The following is a description of a gene set: Human Gene Set: GOBP_BIOLOGICAL_PROCESS_INVOLVED_IN_INTERSPECIES_INTERACTION_BETWEEN_ORGANISMS species: Homo sapiens Any process evolved to enable an interaction with an organism of a different species., and this is the list of marker genes: NPC2, ZDHHC18, CCR5, NECTIN2, B3GALT5, RFPL2, TTC4, SPRR2A, TRAF2, PRKCE, PLA2G2A, NECTIN1, CXCL2, CYP1A1, CALR, TUSC2, TRAV1-2, CTSS, AVPR1B, BCL2, PTPN11, APOBEC3B, PTPN22, DUOX2, KPNA6, MEFV, SSC5D, KAT5, CD40, TRIM10 (NCBI Gene Id 95309), USP20, REG1A, HDAC2, NLRC3, CARD17P, UMOD, KLRC3, CCDC186, ZMYND11, SLC15A2, DEFB105A, STOX2 (NCBI Gene Id 93007), PSMA2, FKBP5, DEFB112, STMP1, MIR6869, PPP1R11, KLK7, MAP2K7, IFNL2, SASH1, NAPEPLD, PML, GKN2, CHMP4C, USP44 (NCBI Gene Id 84101), AP1G1, CARD9, COL6A1, KLHL6, NOTCH2, TRIM3, CCL19 (C-C motif chemokine ligand 19), DEFB133, SPAG11B (sperm associated antigen 11B), CFHR2, CCL7, NRP1, GARIN5A, PTPN2, NFKB2, HSPA8, EXOC1, THRSP, UBL7, MOG, NCAM1, TBXA2R, GPC3, SLC9A9, PLSCR4, TAB3, GRK2, LETMD1, SHMT2, CXCL13, CD300C, MIR520B, WWP1, MX2, TRIM54, C1S, RAB27A, WFDC2, NCR1, NR4A1, CHIT1, RAB20, YTHDF2, NLRC4, TRGV3, NOS3, PIK3C2G, CHMP1A, AXL, CCL4L2, CLEC2A, CDC73, TRIM49D2, PC, ITCH, IFNA4, DEFB1, FASLG, MIR146A, DEFB116 (NCBI Gene Id 245930), TSPO, PSMC3, SIGIRR, DEFB113, HTR2A, IFNL4, C4BPA (complement component 4 binding protein alpha), PPID, VAV1, CASP6, C9, ACTA2, GNLY, STXBP1, IFNA21, APOBEC3F, RAB14, CFH, CLU, TUBB4B, CD300E, SLC38A8, XPR1, SMPDL3A, TRIM25, TMEM126A, CAV1, EDN1, ITGB3, IRF3, TRAF4, PARP9, HCK, CSNK1A1, SEH1L, RPS6KB1, DEFA3, ARHGEF2, UVRAG (NCBI Gene Id 7405), TBX21, DEFB128, DDB1, TRIM4, EVPL, TREM1, AP1S1, DDX41, APOB, PSTPIP1, STOM, DUSP10, ULBP3, C8A, ATAT1, SIGLEC10, BPIFA2, MIR675, ADAM8, LITAF, MFHAS1, BTK, RPS6KA3, DEFB115, SH2D1B, IL33, FCGR1A, IDE, ATG5, PCBP2, VGF, FOS, WIPF1, DEFB103A, ERBIN, IFIT1, MARK4, IGHG2, AP3B1, PTPN6, IL17RC, NPLOC4, IL34, EEA1, INPP5K, CCL3, DAB2IP, MIR17, ADAM9, VAMP4, PLCG2 (NCBI Gene Id 5336), HRAS, CCDC92, DAPK3, NDUFAF4, NR1H3, TRIM26, IL17F, TLR5, DHX33, TARBP2, LAG3, IKBKB, HYAL1, ABCC8, IDO1, TRIM62, TOMM70, KIAA0319L, TICAM2, XCL1, NOD2, TRIM29, NLRP9, DEFA6, PMAIP1, SIRPA, NOTCH1, UNC13D, LYN, IL17A, APOBEC3A, MUC2, RAG2, WNT5A, NUGGC, LCE3C, ADAMTS5, TRIM11, FCRL3, BPIFB1, FAM3A, C1R, STAP1, NLRP2B, ACOD1, PELI3, OAS1, LCN2, TNFRSF1B, CPTP, SLFN13, SLC19A1 (solute carrier family 19 member 1), NOD1, TARM1, UBD, TBC1D20, STAB1, UFD1, MIR421, HLA-E, IGHG1, SYT11, IRAK2, EPX, GPR108, KLRC1, IL37, TICAM1, IL18, MLH1, ZBTB1, IGHE, SCARB2, COTL1, LILRA4, ABCA1 (ATP binding cassette subfamily A member 1), DAPK1, CTSL, CD47, PLPP6, CREBZF, SIGLEC1, CD2AP, NLRP1, ZDHHC20, IFNL1, ZCCHC3, KIR2DL4, DEFB114, SLAMF6, LY96, CD86, ANXA1, VWCE, HAVCR2, PRKN, FZD5, N4BP3, TRIM77, TRIM34, BATF3, FCER1G, C1QB, PAF1, ABCC9, KRT6A (NCBI Gene Id 93086), STMN1, PARP14, SPSB3, RNASE10, KCNK6 (potassium two pore domain channel subfamily K member 6, NCBI Gene Id 9424), TRIM64B, IRF5, AIM2, WFDC12 (WAP four-disulfide core domain 12), MED1, STING1, VPS18, FBXO9, CD81 (NCBI Gene Id 975), CD160, IFIT2, C6, RARA, CXADR, FYN, NLRP3, TKFC, MATR3, JAK3, TASL, OGT, TRGV4, RNASE12, VAPB, AKT1, DEFB135, TRAF3IP1, TGFB1, CHMP2B, F12, SLC46A2, RNASEL, UAP1, OPRK1, SP1, GLI2, NFKBIA, CCL21, CAPN2, TRIM43B, FCAR, ISG20, LSM14A, FBXO3, SLC1A5, MIR223, CCT5, CXCL1, CD46, CHMP4B, CD68, SERPINB3, IFNA10, IFNE, TLR2, USP15, DAO, MX1, TRIM23, SMARCB1, STAT2, RAC1 (NCBI Gene Id 5879), CST9L, CHRM2, MIRLET7I, CD58, GPAM, MOV10, TREX1 (three prime repair exonuclease 1), CR2, C15orf48, CBL, CD74, NQO1, LRAT, SMPD1, SLAMF8, C1RL, KIR3DL1, NUB1 (negative regulator of ubiquitin like proteins 1), KRT1, CRIPTO, TNFAIP3, MIR19B1, BPIFA1, C1QBP, DEFB131A, HLA-G, RNF144A, TRIM32, PLAA, CHMP6, PRKCD, GBF1, FURIN, ZDHHC11, ANPEP, PPP6C, LATS2 (NCBI Gene Id 95108), ARMC5, BPIFC, TRAV10, HMGB1, SBNO2, PI3, APPL2, DEFB108B, CTSG (NCBI Gene Id 1511), PUM1, EPS15, MAP3K7, CNOT7, DRD2, IL1RL2, TREM2, BCL3, EXT1 (NCBI Gene Id 3966), LYPD8, ZNRF4, TAB1, LILRA2, RAB7B, HK1, DEFB129, WFDC3, IRF2, DEFA4, CADM1, POLR3A, NPPB, UBA7, LRRC15, PRDX2, IFI44, EEF1G, WASHC4, DEFB104A, LTF, VAMP8, TRIM35, H2BC4, MIR200B, LEP, SUSD4, BIRC2, NCBP1, HPGD, EFNB2, PPARD, ECSIT, SYNCRIP, WFDC13, TRIL, GNRH1, CYBB, TARDBP, MAPKBP1, KYNU, MICB, MIR758, LDLR, WDFY1, TMEM120A, IFNG, SYK, CFD, LAMP1 (lysosomal associated membrane protein 1), NAALADL2, IL18RAP, CSNK2B, KLRC2, STAT1, CACTIN, AUP1, POU2F2, CD300H, NTS, PLG, WDR83, CHMP2A, TMEM229B, PPBP, EIF4E2, HP, AKAP12, TENT5A, RNF213, VAPA, IGKV3-20, LGALS3, ULBP1, FAU, FER, PDCD4, CD2, RBM47, LYST (NCBI Gene Id 1130), ZDHHC3, INPP5D, ESR1, IL10RB, HPGDS, ATG12, DEFB119, TRGV9, VNN1, TRDV2, TMF1, CDK6, EPRS1 (NCBI Gene Id 2058), RNASE8, DEFB105B, DEFB123, H2BC6, CST9, TFAP4, GBP5, DEFB103B, HSP90AA1, CCL24, GPR15LG, GJB6, HLA-B, HES1, FLNB, JAGN1, CHD7, CDK9, GPX4, EIF2AK4, NMI, PDE4B, WFDC10A, TRGV2 (NCBI Gene Id 6974), ZFP36, TRIM63, LRRC19, GIGYF2, CD55, SETD2, SERPINE1, KNG1, CCL15, SLC3A2, OTUD5, FABP4, RELA, EPHB2, GFI1, FGF10, IFNA17, STXBP2, POLR3D (RNA polymerase III subunit D), LY86, CORO1A, CX3CL1, CCL17, BANK1, AGBL5, GBP3, TRAV5, STAT5B, HMGCS2, RAB1A, APOE, OASL, MIR20A, DEFB124, LCE3B, HSPD1, CASP8, PIK3C3, TRIM27, CHMP3, XIAP, SCGB1A1, VIL1, H2BC8 (H2B clustered histone 8), CFL1, TRAF3IP2, FCGR3A, ADAR, REG3G, RNF19B, IFNA16, IKZF3, IL24, RNASE3, TRIM38, DEFB127, PDCD1LG2, CD1D, TNF, RNF5, SERINC5, MIR187, HLA-F, TRDV1, RFPL4B, DEFB107A, SHC1, TMEM45B, CLEC4A, PTGIR, TLR6, GTF2F1, MIR221, CLDN2, H2BC12, FADD, SHPK, DEFB108A, HIF1A, TPCN2, SRPK2, XRCC5, PRG2, MARCHF5, CLNK, MIR21, LACRT, GZMB, RNF216, CLDN9, KPNA3, IFNLR1, DAG1, ITGB6, VIP, PYDC5, ELMOD2, ADAMTS4, KCNJ8, MAP2K6, SPON2, RTP4, AKAP8, IL13, INSR (NCBI Gene Id 3643), IFITM2, LYPLAL1, HDAC6, KLRK1, TIFAB (TIFA inhibitor), NCF1, KIR2DS2, PPP2R3C, DROSHA, KCNK13, PGLYRP3, SPI1, SFPQ, RAB11FIP2, MIF, TRAV34, TRIM41, VPS37B, ATAD3A, ITGA2, WFDC10B, TPCN1, PVR, YTHDC2, NCBP3, SNX3, PYGL, DEFB121, AARS2, LYZL4, PRTN3, BNIP3, PPARG, PDPK1 (NCBI Gene Id 5170), LATS1, CHMP5, KIF5B, EIF2AK2, DDX1, NR1H4, AIF1, PLAC8, PCK1 (phosphoenolpyruvate carboxykinase 1), IL6R (NCBI Gene Id 3570), RPS15A, SAP30BP, WDFY4, UBE2K, TNFSF4, TRIM17, GSTP1, PTGER2, IFNA7, CRTAM, TLR10, ZNF502, UBQLN1, CDHR3, APCS, IFI16, LAMP2, SCNN1B, C4B, KLK3, KMO, ROMO1, REST (RE1 silencing transcription factor), BAX, ALPK1, SELPLG, TLR8, RNF39, ALAD, RFPL3, CXCL12, RAB5A (NCBI Gene Id 5868), SLC17A5, MR1, MIR766, ATG16L1, BRD4, IFIT1B, IFNAR1, LYZ, EGFR, MICA, ZDHHC12, H2BC10, ILF3, MSRB1, RBPJ, EFNB3, PGLYRP1, KRT16, RBCK1, IL10, DEFB106A, FN1, RNASE6, APOBEC3H, HMGB3, RNASE2, AIMP1, ZDHHC8, CHMP7, IFNA5, FBXL2, IER3, BANF1, APP, PF4, TMEM106A, TNFAIP8L2, GDI1, OAS3, ZNF697, RNF166, SLC15A4, MPO, LRG1, IL36B, TRAV20, RAB43, USP38, CYBC1, REN, GATA3, HTN3, PI4KA, ADH7, PIK3AP1, DHX58, RFPL4AL1, IL10RA, FOSL1, DHX16, CLEC5A, TNFRSF1A, ST13, SLC26A6, MAPK8, UNC93B1, GPS2, CD300LF, WAS, HVCN1, LRCH4, ABHD8, JAK1, SMIM30, IFNK, ZC3HAV1, LILRB1, NAGK, PSPC1, MECP2, NCF2, NMB (NCBI Gene Id 4828), PUM2 (pumilio RNA binding family member 2), HMGB2, PLA2G1B, ZNF683, HTN1, DMBT1, ACP5 (NCBI Gene Id 54), IPO5, NT5C3A, TLR7, CDC42, CD4, TRAV7, IKBKG, KRT8, TRIM28, ULBP2, RAF1, RFPL4A, CHMP1B, MIR30C1, RBBP9, IFI6, SFTPD, LGALS8, MIR200C, NCK1, AURKB, IPO7, MRC1, LGALS1, SLC30A8, HYAL3, NLRX1, CYSRT1, ITLN1, OPTN, DCST1, ANKRD17, MYH10 (NCBI Gene Id 4628), CFHR1, IFIT5, LRSAM1, HDAC1, MAP3K5, ABCF3, HNRNPUL1, IFNGR1, ILRUN, PPM1B, ANKRD1, DDX39A, LALBA, CD79B, ZYX, CSF3, DEFA5, IGF2R, NCR3, CLDN3, PPP1R14B, MMP12, CEP192, MIR4691, GIT1, CLDN1, APOA4, SERINC3, DEFB130B, MIR224, IFIH1, DEFB107B, TANK, GALP, FGFR2, CCL8, USP14, C5, MASP1, HSP90B1, PRLR, GSDME, RNF135, H2BC11, B2M, TRIM44, NOS2, CCDC88B, CLEC4C, SELENOW (NCBI Gene Id 6415), S100A9 (NCBI Gene Id 6280), SLFN11, LCE3A, CXCL11, TRIM40, TMEM43, MAPKAPK2, EIF5A, CHID1, ODC1, ABCD2, COLEC11, P2RX7, PIK3CG, RFPL1, NFKBIL1, HS3ST5, LGR4, MIR105-1, PIK3R6, VCAM1, FMO1, UPK1B, DCD, ATG14, JUND, TRIM14, TAX1BP1 (Tax1 binding protein 1), EREG, TMEM33, TF, IFITM3 (interferon induced transmembrane protein 3), CDK1, RASGRP1, RAB7A, RHEB, LPL, BPI, FGB, CCL3L3, TRIM49B, CASP7, MCOLN2, TREML1, PF4V1, TLR9, ARF1, EPG5, NLRP7, CEACAM1, TRIM49C, BECN1, EMILIN2, TAP2, RNASE11, TTLL12, C2, HMCN1, IL15, HLA-A, ELANE, NUP153, IRF1, ARG1, CTSB, CD96, CDK4, TRIB1, CCL27, ZNRF1, ZG16, MYD88 (NCBI Gene Id 4615, MYD88 innate immune signal transduction adaptor), ASS1, HLA-C, EXOSC4, PRSS2, HSP90AB1, FER1L6, BNIP3L, TRIM61, AQP1, GAPDH, EEF1A1, SEC61A1, ZNF175, TNFRSF4, F2, PHB1, MIR433, TRIM64, TRIML2, ANXA3, SLC52A2, CXCL9, USP7, ZC3H12A, DEFA1B, ERAP1, CTDP1, CD14, GSDMB, WRNIP1, CDC42EP4, AKIRIN2, PGLYRP2 (peptidoglycan recognition protein 2), CEP63, TMED1, HSPA1B, ITGAM, NFE2L2, SCIMP, STXBP4, KYAT1, SERPING1, GRB2, IFI35, MAPK14, DDX56, TRIM49D1, CSF1, SLC30A1, HEATR9, CXCL14, PAIP1, TRAV13-1, DEFB109B, OTOP1, MMP7, RASGRP4, TMEFF1, IL22RA1, AKAP1, BTBD17, PLA2G2F, PRKD1, PABPN1, TRIM51, RNASE7, RPS19, PRF1, BPGM, MYH9, IL1RAP, SERPINB4, SDHAF4, CCL26, TLR4, ITGB5, HPX, HDAC5, BST2, GPM6A, LSM5, CEACAM20, DEFB4A, SAMHD1, IFITM1, PQBP1, RAET1G, MIR26B, DEFB118, FCER2, ANG, SAMD9 (sterile alpha motif domain containing 9), N4BP1, SEC14L1, CD300A, DEFB110, MARCO, CLDN6, IFNA1, C7, PPM1E, CA5B, MAPK1, TYK2, CASP4, PRSS3, FOXP3, CFB, DHX36, PLEKHM2, USP50, CCL16, TRDV3, MIR181B1, IL36RN (NCBI Gene Id 26525), MIR95, BMP6, TRAV25, TRIM65, VEGFD, SPAG11A, TRAV4 (T cell receptor alpha variable 4), GPATCH3, IL36A, HERC6, CIITA, SRC, S100A14, NR1H2, EPO, GPR146, LYZL6, PCK2, SPN, BATF, PELI1, NR1I2 (NCBI Gene Id 8856), CYRIB, IFI44L, MAP2K3, KLRF2, TRIML1, CCNT1, NEK7, IFNA6, RPSA, FPR2, CYBA, DNAJC3, TRIM15, CAMP, PLD4, MST1R, RNF125, PGC, TAB2, TMEM255A, CXCL16, S100A7, TBKBP1, ADGRB1, NAIP, NR1D1, ADH5, TRIM5, MID2, MTOR (mechanistic target of rapamycin kinase), PPM1D, CCDC134, CALM1, IFNL3, FMR1 (NCBI Gene Id 5421), FFAR2, CTR9, KLRF1, S100A8, SH2D1A, CD37, GBP6, UPF1, MIR545, IL18BP, LAMP3, MIR141, LCN10, RAB29, DDIT4, CX3CR1, BCL2L1, CCL23, LDOC1, IGHA2, STX8, CLEC12B, TRAV27, JAK2, SKP2, CNPY3 (canopy FGF signaling regulator 3), TRAV35, PLA2G10, TRAV6 (T cell receptor alpha variable 6), IRF7, LAMTOR5, SMC6, CR1, CD209, TRAV26-1, DDX60L, PHB2, C3, SLC7A1, IGHG3, HPN, MALT1, CAV2, RIPK3, FBLN1, CHMP4A, HMGN2, CD6, APOL1, HEXIM1, FLOT2, CLEC4G, LGALS9, CSNK2A1, HAVCR1, SNW1, WFDC5, ERCC6, BCR, UBE2L6, UGT2A2, RNASE1, BSG, NECTIN4, CALCA (NCBI Gene Id 87044), TRAF6, KLK5, IL27, NLRP4, CSF2, NEDD4 (NEDD4 E3 ubiquitin protein ligase), IFNA8, ZNFX1, TRIM73 (tripartite motif containing 73), RNASE9, A2M, RBM14, CASP9, FASN, ARID5A, H2BC12L, CUBN, LPO, IL36G, TRAV1-1, MBL2 (mannose binding lectin 2), PPARA, NFKBIB, F2RL1, RNASE13, RPL39, LILRA5, IL31RA, PARP1, PLAAT3, IRF8, CGAS, CST9LP1, F2R, TRIM55 (tripartite motif containing 55), SHFL, GZMH, TLR3, RPL30, CCL14, FCN2, IL7R (interleukin 7 receptor), WWP2, CD244, CPT1A, HLA-DRB1, CRK, C4A (NCBI Gene Id 720), IGHD (immunoglobulin heavy constant delta), E2F1, BATF2, RRP1B, CLEC10A, MIR222, GSDMC, IRGM (immunity related GTPase M), PRKCA, HERC5, DEFB125, CXCL3, TRIM22, INS, C5AR1, RAB2B, TRIM6, ZDHHC5, MAP3K14, CCL2, EXOC7, ELP6, HADHB, LRP8, CH25H, CDK19, ENDOD1, ABCB1, ST6GALNAC1, TRIM69, CD80, EPHA2 (EPH receptor A2), RHOA, CCL18, TAC1, YWHAE (tyrosine 3-monooxygenase/tryptophan 5-monooxygenase activation protein epsilon), GATA6, GPER1, ADAMTS13, NINJ1, SERPINB9, DNAJA3, ITGB8, EXOC2, MMP8, APPL1, PPIB, PAK1, ACE2, DEFB136, TSLP, TRIM7, AVP, NLRC5, TNFSF8, FLOT1, LRRC14, SLPI, NMT2, CASP1, RPL13A, TNFRSF14, IL17RA (NCBI Gene Id 23765), PTPRC, CD207, IL25, TRAV26-2, RNASE4, ACTG1, NT5C2 (5'-nucleotidase, cytosolic II), ENO1, LYG1 (NCBI Gene Id 129530), CCL1, MIRLET7B, CMPK2, TRIM50, TRIM52, DTX4, LYG2, IKBKE, OTULIN, ATP4B, SCN7A, IFIT3, TRAF3IP3 (NCBI Gene Id 80342), GRN, CREBBP, S100A12, TLR1, CEBPE, CLPB, FCN1, CXCL5, STXBP3, HNRNPA0, CD274, NPC1, RIGI, GHSR, MIR520E, NEURL3, GSDMD, EDNRB, CARD8, REG1B, IFI27, IL6, CRCP, KPNA2, HCST, RSAD2, AGBL4, DEFB104B (defensin beta 104B), CSF2RB, ATF2, IFNW1, GZMA, SHARPIN, GBP2, TRAV30 (NCBI Gene Id 28652), PPP2CA, TRIM75, IL12A, ITGAV, PLSCR1, MEF2C, TRAC, REG3A, IL23R, POLR3G, ZDHHC1, TRIM64C, ATG7, CXCL6, IFNGR2, TRIM58, MAPK3, SARM1, PCYOX1L, CCL5, IL12RB1, CDC37, TOLLIP, NFKB1, PENK, BAK1, NRROS, WFDC9, IL21, SELENOK, KLRG1, PIM2, NECTIN3, FCGR2B, NOP53, CYLD, SLC10A1, DEFB130A, TRIM51G, CCL4, CD177, CPS1, IL4R, NOCT, MYO1C, CEBPB, CCL11, POLR3K, MIR128-1, SMAD6, FGL2, ADAM15, PTAFR, PRB3, PGLYRP4, CCL28, METTL3, NLRP6, PAK3, SLC7A5 (NCBI Gene Id 8140), MIR149, VPS4A, F11R, TMEM41B (transmembrane protein 41B), RDUR, BCL10, GCH1, CHGA, TPT1, DYNLT1, DDX17, TNIP1 (TNFAIP3 interacting protein 1), DEFB134, MTDH, COLEC12, ITGAX, TUBB, MIR140, DCLK1, TRGV8, KLRC4, LY9, CXCL10, CFHR5, AGTR1, MACROD2, NMBR, PIM1, INAVA, ZFYVE1, IRAK3, ITGB1, BSPRY, PJA2, KLRD1, HLA-DPA1 (NCBI Gene Id 7935), POLR3B, PLSCR3 (phospholipid scramblase 3), TRIM59, MAP4K2, RTN4, MUC7, ABL1, CCNK, CFI, PTGFR, IL1A, PIK3CD, DDX3X, CSF1R, PTPRS, UGT2A1, IFNB1 (interferon beta 1), TBK1, ITGA5, IFNA14, H2BC21, SNCA, IFNA2, PDE12, AICDA, LOXL1, HYAL2, SENP7, MIR342, SEMG1, TRAF3, DPP4, SLC52A1, CLEC4D, CEBPG, STX4, NKG7, TRIM56, ZBP1, PTGER1, DEFA1, TRGV5, MIR29B1, TRIM74, CCL20, PADI4, POU2AF1, AZI2, H2BC7, IGHA1, LGALS4, LYAR, WASL (NCBI Gene Id 8976), BMP2, VTCN1, TYROBP, STATH, ARG2, DEFB132, FAM20A, CFP, EP300, MMP3, CYP2E1, ZDHHC9, TRAFD1, SEC11A, LIAS, CHUK, DHX15, SRR, RAET1E, BPIFB3, STAT5A, KLRC4-KLRK1, PPIA, DUS2, CHMP4BP1, GYPA, USP29 (NCBI Gene Id 57663), LILRB2, PALM3, ADM (NCBI Gene Id 133), EPPIN, DEFB126, MGST2, MIR142, TRIM13, G3BP1, CRISP3, TRIM49, DHX9, CXCL8, PYDC2, PYHIN1, TRAV21, LACC1, SRPK1, CYP27B1, ITGB7, TRIM48, ACTR3, PPT1, ATP1B1, ZMPSTE24, SELENOS, TRIM43, NLRP10, PTPN1 (NCBI Gene Id 5770), POLR3C, SLC15A3, LTA, USP27X, SEMG2, GBP7, MIR19A, TP53, AQP4, PYDC1, GZMM, SMARCA4, CCL22, TRAV13-2, HSPA1A, SIN3A, TRIM8, NPY, TXK, CD84, TRAV36DV7, WFDC11, CCDC80, ICAM1, CALHM6, SQSTM1, LY6E, GBP4, GRAMD4, DIO2, THBD, CLEC4E (NCBI Gene Id 26253), SFN, IRAK1 (NCBI Gene Id 3654), POLR3F, CAMK2A, POLR3E, BDKRB1, TRIM60, SLC10A2, CARD16, POU2F3, ACTR2, CASP3 (NCBI Gene Id 836), VAMP7, HSPB1, HCFC2, GATA1, ARRB2, NFIB, TFEB, ZDHHC11B, TSG101, SIGLEC16, TREML4, TRIM72, CLEC4M, RELB, IL12RB2, MASP2, ADIPOQ, IL1F10, TNFRSF11A, IVNS1ABP, MORC3, SP100, RNASEK, MAPKAPK3, MIR708, C1QA, UBE2W, NLRP2, FOXP1, MAPK11, SLAMF1, GPX1, GSDMA, VPS26B, RNF34, JPT2, NOS1, RARRES2, TNIP3, GSTCD, CLEC7A, POMC, SMAD3, AZU1 (azurocidin 1), TRIM31, GPR15, USP17L2, DDX21, CD200, HSF1, CST11, RFTN1, INHBB, ISG15, YWHAZ, RNF170, P4HB, SMPDL3B, IL12B, RIPK2, POLR3H, RIOK3, RNASET2, IRF9, CD180, XBP1, FUCA2, MUL1, RB1CC1, COLEC10, ZNF639 (zinc finger protein 639), CXCR4, NUCKS1, BIRC3, MIR130A, SPIRE1, MAVS, PLA2G6, G3BP2 (G3BP stress granule assembly factor 2), XCL2, HMGA2, ATG9A, TSPAN6, TRIM21, SCARB1, TFRC, MLKL, XRCC6, RGS1, FCN3, SIRT2, PRKDC, CD226 (NCBI Gene Id 10666), IGHM, CD36, FGA, YJU2B, PIK3R1, CNR2, VAMP2, ABHD17A, LBP, TRIM39, ADARB1 (NCBI Gene Id 104), PRDX1, USP18, BRCC3, CRP, GPR31, TIRAP, PTGS2, CITED1, UBE2N, ARL8B, CCL25, C1QC, TIGIT, MMP9, MS4A1, CCR7, YTHDF3, NONO, SLC20A2, DTX3L, TOR2A, OAS2, GBP1, MMRN2, ZBED1, PLA2G5 (NCBI Gene Id 5322), NFKBIZ, VPS4B, ROCK2, CREB3 (cAMP responsive element binding protein 3), SLC22A5, CCNT2, REL, IL23A, GAS6, CA3, C8B (complement C8 beta chain), OCIAD2, MARCHF2, TRAV17, TMPRSS2, SMC5, JUN, PTX3, SPINK5, TNIP2, TRDN, LEF1, GSN, IFNAR2, URI1, C8G, OTUD4, TRAV24, LEAP2, PAK2, ALPL, APOBEC3C, REG4, IL27RA, CDH1, VSIG4, CCL13, SMARCA5, HDAC4, TRAV39, SELP, CD24, CLPS, PYCARD, PIKFYVE, HAMP, APOBEC3G, RNF26, FOSL2, STAB2, CALCOCO2, TRIM68 (NCBI Gene Id 55128), C4BPB, ZDHHC4, CLEC6A, SELE, FGR, IGHG4, PRDM1, RNF185, VIM, PRPF8, SCARA3, SLC11A1, PRDX3, RNF115, CHD1, IL1B, PIK3CB, APOBEC3D, SLAMF7, DEFB106B, NAGLU, TIFA, SIVA1 (SIVA1 apoptosis inducing factor), TAF11, PRKRA, SOD2, DEFB131B, DDX60, HRG, EMILIN1, EXOSC5, JCHAIN, IRAK4, ADAMTS9, CDC42EP2, MIR302A, MIR210, MPEG1, MNDA, ANKHD1, ADAM17, TYRO3, FGF19, IRF4, RNF31, GP2, TMPRSS4, TSPAN32, KLRB1, AHR, VAMP3